Given this list of marker genes TSHR, GFAP, BANK1, CHEK2, MPL, CBL, PRKAR1A, ACADM, SLC25A11, NRAS, STAT3, ATP7B, ANO1, NNT, STAT5B, PSAP, DAO, CNTNAP1, FLI1, FANCD2, BCOR, ERBB3, TMEM127, RUNX1, DNMT3A, AAAS, GATM, CENPE, MAP3K20, AVP, BCL2, MDH2, RPS20, LMNA, SPINK1, WT1, C4A, NAB2, SNCA, CEP152, ERCC5, PXK, SMAD4, ANXA11, LIPA (lipase A, lysosomal acid type), PLK4, PON2, PPARGC1A, GABRA3, EIF4G1, UBE2L3, CDKN1A, RARA, PANK2, ABCD1, NF1, FANCG, SCNN1A, NEFH, IL23R, TNFRSF1B, HTT, SLX4, PTPN2 (NCBI Gene Id 5771), CDC73, TRIM28, GPR35, KIT, TGFBR2, VAPB, RBBP8, BAP1, MAFB, BTNL2 (NCBI Gene Id 56244), PCNT, GBA1, TRIP13, MSH2, MLX, FAS, TRIM37, NOD2, CD28, NEK1, KLRC4, DIS3L2, TXNRD2, HSPG2, TPM2, UBQLN2, LIG3, DCTN1, TPM3, CIITA, RHBDF2, PIK3CA, FOXP1, CHMP2B, ERCC2, PALB2, SCNN1B, XRCC2, TET2, SEMA3C (NCBI Gene Id 222200), ATM, JAZF1, HLA-DPB1, SREBF1, BCL10, ZNRF3 (zinc and ring finger 3), PIK3R1, EWSR1, TRPV4, JAK2, HFE, BRAF, MST1, SLC34A1 (NCBI Gene Id 8561), AMN, MATR3, CDH23, GNPTAB, THPO, HLA-B, NR0B1, TYMP, CRLF1, GJA1, GJB3, FANCC, MECP2, BTK, MUTYH, GALC, FANCF (FA complementation group F), DNAJC13, FANCB, VPS13A, PML (NCBI Gene Id 5371), RABL3, MYCN, SLC6A8 (NCBI Gene Id 6535), CD244, SIGMAR1, CTLA4, RILPL1 (NCBI Gene Id 353116), NUMA1, VCP, TLR4, CDKN2A, FANCL, ITGAM (NCBI Gene Id 3684), ALK, ATP7A, PMS2, CACNA1S, HLCS (holocarboxylase synthetase), RRM2B, PERCC1, TERT, IL10 (interleukin 10), FANCE, GDNF, REST, GCK, NUP85, SOD1, TARDBP, KDSR, IL12A-AS1, KIAA0319L, KRAS, KRT1, HMGCL, MEN1, STAT6, KLF1, FUS, TRAPPC11, SDHB, RAD51, EDNRB, TGFB1 (NCBI Gene Id 7040), ERCC4, IRF4, UNC13A, PTPN22, CTRC, INS, ABCC8, CD247, SPTLC1, ATRIP, ACAT1, SLC34A2, ECE1, TNFAIP3, EPAS1, IKZF1, ERBB2, SLC2A3, SPG11, ATRX, HACD1, TP53, UBE2T, GJB4, LRP12, CDKN2B, SPP1, TAF15, MRAP, KCNJ18 (NCBI Gene Id 100134444), COL4A6 (NCBI Gene Id 1288), BIRC3, RB1, CDKN1B, PRNP, IGHG1, ASXL1, POLD1, VHL, ATR, CCR1, EPCAM, MAX, ELF4, ERCC3, SMO, SDHAF1, F5, EDN3, TNFSF4 (NCBI Gene Id 7292), IFIH1, SQSTM1, DLST, OPTN, CCNF, HLA-DRB1, IRF2BP2, PFN1, GLE1, HACE1, BCL6, FCGR2B, FH, NBN, FANCA, AK2, NALCN, CCND1, IL12B, GIGYF2, KIF1B, LRRK2, STAT4, UBAC2, FCGR3B, NRTN, FOXP3, CALR, MAP2K1, RET, MEFV, SLC39A4, BRCA2, SEMA4A, SDHD, NABP1, RNF168, GMPPA, TNIP1, PTEN, KCNJ11, TBK1, C4B, COL4A5, MC2R, HLA-DQB1, CFAP410, BLK, CUBN, GIPC1, IL2RA, HNRNPA1, ACTA1, SDHAF2, PDX1, KRT10, SCNN1G, STAR, RAD51C, RRM1, TRAIP, CYP24A1, PALLD, TBL1XR1, CTNNB1, BMPR1A, NDUFAF6, FIP1L1, LIN28B, ETS1, MSH6, CR2, BRCA1 (NCBI Gene Id 672), IL2RB, JPH3 (junctophilin 3), SLC5A1, GLT8D1, PRPH, ZBTB16, GPC3, GATA4, POLE, TREX1, RNU7-1, P4HA2, STAT1, IFNGR1, NPM1, SYK, VPS35, SEMA4D, SRSF2, TREM2, ALS2, PON3 (paraoxonase 3), AKT1, IRF5, SDHC, HLA-DQA1, GATA2, BMP6, PRTN3, IVD, FIG4, MYL2, UNC45A, ABCB7, TWNK, PKHD1, FANCM, PHOX2B, POLG (DNA polymerase gamma, catalytic subunit), ERBB4, SDHA, IRAK1, TLR7 (NCBI Gene Id 51284), BMP4, DNASE1, IL12A, HAVCR2, PDCD1, ANKRD55, IL6, BRIP1, VPS13C, SUCLA2, POU6F2, CTNS, ITGA7, SEMA3D, STUB1, PMS1, B2M, MLH1, UNC80, CFTR, LPIN2, TCF4, TTR, EHHADH, CHCHD10, NOS1, NOTCH2NLC, DNA2, PON1, NDP, ATXN2, ANG, RFWD3 (ring finger and WD repeat domain 3), LMO1, SELENON, CUL4B (NCBI Gene Id 8450), MAD2L2, ZMPSTE24, CDKN2C, H19, SLC22A4, NFKBIL1, FANCI, MALT1, SLC9A6, HLA-DPA1, ERAP1, here is a description of the gene set: species: Homo sapiens Weight loss Human Gene Set: HP_WEIGHT_LOSS Reduction of total body weight.